Given this list of marker genes ERGIC1, PRKAG2, ADD2, ASIC1, THEM5, NRF1, NAA40, OSBPL3, PPP1R15B (protein phosphatase 1 regulatory subunit 15B), RAVER1 (NCBI Gene Id 170590), BCAT1, MB21D2, KPNA3 (karyopherin subunit alpha 3), EFEMP2, GNG4, VGLL4, C8orf58, RETREG2, KRT73, IGF2BP3, GGT6, PLXNB1, SCAMP2, NLRP2B, CELF4, SLC45A4, THSD7A, UBE3B, ARHGAP1, USP12, PPEF2, SOCS3, TET3, SLC25A37, KHK, MPV17L, EFHC1, SUFU, NSL1, FAM168A, PABIR2, GSTM2, TBC1D24, SMARCD1, FSTL3, PLXNA2, ZFX, DPF1, PRAMEF14, PLEKHH1, EFNB3, TIMM9, M1AP, TPBG, VPS52, DGKA, PDE7A, PROM2, EME1, SMIM12, ASB6, PKDCC (NCBI Gene Id 91461), WNT5B, ZNF850 (zinc finger protein 850), ZNF264, SUDS3 (SDS3 homolog, SIN3A corepressor complex component), RHD, THBS1, NF2, RGS7BP, CHST1, PSD2, TAFAZZIN, CELF3, ALS2CL, FGD6, BET1L, RTCA, RPP30, CPEB3, DPY19L1, SLC2A11, GOLGA6L1, EMSY, ISLR2, ZNF490, NR6A1, IQSEC2, PIM1, MAPK1IP1L, AHR, ERF, NUTF2, BSN, NAALADL2, STK39, FKBP1B, CDH7, SHISA7, IL11, NEK2, C19orf12, PRPF40B, CFAP97, HOOK3, KIAA0930, SPRED1, FAM83H, ZER1, ZNF528, C14orf119, TRIM37, SLC11A2, PNKD (PNKD metallo-beta-lactamase domain containing), USP46, MSMO1, INSM1, DESI1, KCNK4, RAE1, OR2H1, EGLN3, GFOD2, THAP12, CREB5 (cAMP responsive element binding protein 5), TAT, SERP1, KY, STAT5B, MTFR1L, BEST3, CYP2B6, VCL (NCBI Gene Id 7414), STEAP3, CBFA2T2, KMT2A, ERBB4, C9orf57, EIF2AK2, MAPKBP1, CEP350, KIAA1755, RASAL3, PCSK5, COBLL1, SUPT6H, FAM98B, JPH3, TRIM26, LHPP (phospholysine phosphohistidine inorganic pyrophosphate phosphatase), NHLRC2, SETD1A, CBFA2T3, JAKMIP2, ATG12, SOHLH1, PLCXD1, APAF1 (NCBI Gene Id 317), SPATA18, GHSR, TP53INP2, USP13, PDPN, EYA3, SLC36A2, BCL2L1, LYSMD1, WDR76, FABP3, SPATC1, ELMOD1, OSBPL7, PPM1K, NHLH1, AKAP5, ZNRF3, PARVB, STK35, SPN, PDK3, ADRA2A, TP73, AHCYL2, AFAP1L2, DRAM1, PYGO2-AS1, STON2, IL1RN, TTLL5, PALD1, NOS1, F2RL2, POLA2, RC3H1, RIT2, BMP8A, WNT9B, WDFY2, WDR26 (NCBI Gene Id 80232), LDLRAD4, ADIPOQ, POGLUT3 (protein O-glucosyltransferase 3), CYP19A1, PPP6C, TMEM170A, ZNF154, RBM8A, REEP3, ARHGAP21, ZBTB4, MIDEAS, ZNF253, UGT3A1, GLRX3, MTSS2, INPP5B, DLGAP1, ASTN1, ZNF431, MEF2C, NISCH, SYNPO (NCBI Gene Id 11346), ADAMTS4, LMBR1L, GOLGA6L6, FLCN, ZKSCAN3, EPHA8, ZNF814, RAB14, SLC17A7, ATXN1, CBX5, UST, FCHO2, NAA30, MOB3C, PLEKHA1, RPS6KA4, ALG10B (ALG10 alpha-1,2-glucosyltransferase B, NCBI Gene Id 493903), TMEM30A, KIF3B (NCBI Gene Id 9371), MTCL1, ZNF527, ZSWIM5, ANKH, FRG2C, CDKN1B, TP53I11, CAPRIN2, CACNA1D, INPP5J, DENND1B, ZNF689, BRSK2, WASF2, NUDT19, ZNF587, LY6E, ERMAP, GSK3B, CYTH1, CLEC18A, RBP1, TUFT1, FABP2, DCTN5, RAB41, FAM53C, NAB1, EIF5A2, TAF4B, CNN3, CARNS1, FNTB, NECTIN4, KCNA6, ZCCHC4, ANGPT4, JOSD2, CLCN5, PSAPL1 (NCBI Gene Id 768239), SPRR4 (small proline rich protein 4), MPL, MAGEC1, SARM1, WDTC1 (NCBI Gene Id 23038), IL23R, RBM3, SYT2, SCYL2, LRRC3, WDR7, GTF3C4, SKIDA1, UMPS, LZTS1, SLC5A9, UBE2W, XPNPEP3, TSPAN31, SHISA8, PCGF2 (polycomb group ring finger 2), PLXNA4, GFRA1, EIF1AD, NAV1 (NCBI Gene Id 89796), PGPEP1, UBE2G1 (NCBI Gene Id 7326), PHF19, KDM3B, YWHAZ, GSDMA, GK5, CCDC97, IL10RB, KNG1, IGF1, RNF213, SOX6, BEAN1, PDE4A, MRGBP (MRG domain binding protein), FOXRED2, ARHGAP29, STK40, ZNF346, VDR, LRP8, AWAT2, MTFMT, RNF168, LRP6, NMUR2, PIPOX, MDM2, ETS1, PRUNE2, NAA50, SV2C, ZKSCAN2, TMEM52B, ZNF763, TRIB2, MTR, CYP4V2, PPIL2, MAP9, PACS1, SSH1, UBXN8, PLEKHF2, NFASC, CYP8B1, LENEP (lens epithelial protein), LYNX1, SLC6A5, CPA4, TSPYL4, VAT1, SFR1, RAD52, CLIC6, AP5B1, LIX1L, MYCBP2, PHKG2, NRIP2, B3GAT1, MDM4, POGLUT1, MIF4GD, NDST1, NBPF1, IMPDH1, KIF2B, TUBB4A, SLC35F6, GAPT, ENTPD4, ERVH48-1, IQGAP2, BMAL2, MYC, CASTOR2, ARK2C, LENG8, FAM117B, GGA2, SMU1, FAF1, here is a description of the gene set: Genes predicted to be targets of miRBase v22 microRNA hsa-miR-1827 in miRDB v6.0 with MirTarget v4 prediction scores > 80 (high confidence targets). species: Homo sapiens Human Gene Set: MIR1827 from publication Chen Y, Wang X (PMID 31504780)